Given this list of marker genes Caprin1 (NCBI Gene Id 99144), Dcps, Edc3, Lsm1, Zfp36, Nudt16, Dcp1b (decapping mRNA 1B), Noct, Nudt3, Patl1, Edc4, Dcp1a, Dcp2 (NCBI Gene Id 70640), Cnot7 (CCR4-NOT transcription complex, subunit 7), Nudt12, Patl2, Eif4enif1, Dxo, Pan3, here is a description of the gene set: Cleavage of the 5'-cap of an RNA. species: Mus musculus Mouse Gene Set: GOBP_RNA_DECAPPING